The following is a description of a gene set: Connexins follow the classical secretory transport route from the ER to the plasma membrane: ER -> ERGIC -> Golgi -> TGN (Trans Golgi Network) -> PM (Plasma Membrane). All connexins assemble or oligomerize into hexameric connexons. The site of assembly varies and depends on Cx isoform, or cell type (see Koval et al., 2006).<br>Oligomerization of connexins has been observed during ER membrane insertion (Cx32), just after exit from the ER, in the ER-Golgi-intermediate compartment (Cx26) and inside the Trans-Golgi Network (Cx43). part of: Gap junction assembly studied in species Homo sapiens Reactome Pathway: Transport of connexins along the secretory pathway, and this is the list of marker genes: GJB1, GJA1, GJB2